Given this list of marker genes ITGB1, RGS2, SEPTIN2, ARL6IP5, ATP1A2, ARL6IP1, SLC43A1, SLC43A2, ACE2, TNF, SLC17A8, SLC7A5, PER2, CLTRN, RGS4, PSEN1, here is a description of the gene set: Any process that modulates the frequency, rate or extent of amino acid transmembrane transport. species: Homo sapiens Human Gene Set: GOBP_REGULATION_OF_AMINO_ACID_TRANSMEMBRANE_TRANSPORT